The following is a description of a gene set: Mouse Gene Set: GOBP_REGULATION_OF_FOCAL_ADHESION_DISASSEMBLY Any process that modulates the frequency, rate or extent of disaggregation of a focal adhesion into its constituent components. studied in species Mus musculus, and this is the list of marker genes: Iqsec1, Map4k4, Dusp3, Arf6, Mapre2, Pik3r1